The following is a description of a gene set: from publication Chen Y, Wang X (PMID 31504780) Human Gene Set: MIR219A_5P Genes predicted to be targets of miRBase v22 microRNA hsa-miR-219a-5p in miRDB v6.0 with MirTarget v4 prediction scores > 80 (high confidence targets). species: Homo sapiens, and this is the list of marker genes: CLOCK, UBE3A, ANKRD52 (ankyrin repeat domain 52), TSC22D2, MBNL1, PRKAA2, WEE1, UBASH3B, EYA2, UBE2Z, LPP, SOX6, LGALSL, KCNA4, ASH1L, ZNF561, ROR1, CRLF3, ETV5, CDH1, LAPTM4A, PRDM16, UBR1, TMEM98, RPRD2, CHRNA3, FBXO42, SYT5, SLC12A8, IFT70A, PIGG, PPDPFL, MIER3, PCDH17, CCDC28A, SCAI, EYA1, GRAMD1B, TPCN1, RBM24, IL5RA, MMS19, GREB1, SNRK, RASSF3, PIGR (polymeric immunoglobulin receptor), DNAJC6, MRTFA, THSD7B, S100PBP, RAB35 (RAB35, member RAS oncogene family), PPARGC1A, FURIN, RBMS3, BICRAL, ARMC8, CDYL2, MECOM, STRBP, TBXT (T-box transcription factor T), CC2D1A, PDE4D, FOXJ3, AKAP6, DOK6, LEF1, ANKRD44, HAS3, NR2C2, FAM210B, FBXO3, TENM2 (NCBI Gene Id 57451), SLC41A1, RIMS1, KBTBD8, SLC16A7, SLK, ABHD13, DCBLD2, SSBP2, CNRIP1, ABCB10, TSPAN2, EFNB2, DAZAP1, INPP5J, RAB17, DDAH1, OCRL, SH3D19, ZC3H6, DCAF10, GXYLT1, KCNH8, COL9A1, AKAP13, SEMA4G, CXXC4, ELOVL7, CGNL1 (cingulin like 1), TGFBR2, FHIP1B, LSAMP, SKIDA1, PARD3, BTBD7, ISL1, MFNG, CAMK1D, SDK1, PDGFRA, IL12B, CCNA2, SORCS1, CD164 (NCBI Gene Id 8763), DNAL1, LURAP1L, ZEB2, STK38L, SOX14, ZNF697, PRG4, FAM199X, ADGRE2, CERT1, ZBTB18, ANAPC10, ERG, ATG14, ZNF704, MEF2D, FBXO30, RECK (reversion inducing cysteine rich protein with kazal motifs), CXXC5, SLC39A10, ABRAXAS1, ELMOD2, ARHGAP26, CAPS, DIAPH3, SLC35E1, ADCYAP1, SLC31A1, TRHDE, CLASP1, THRB, CHD7, SLC46A3, KIAA1549 (NCBI Gene Id 57670), TNRC18, TMX4